Given this list of marker genes DLK1, ALG6, SCAPER, SETX, NPHS1, SDCCAG8, CEP19, CAV1, LIPA, FDFT1, RAI1, PNKP, TTC8, BBS10, NUP107 (NCBI Gene Id 57122), IFT56 (intraflagellar transport 56), CELA2A, PIK3R5, ALB, CAV3, PNLIP, CYP7B1, STX5, DYRK1B, CEP290, LRP6 (NCBI Gene Id 4040), PMM2, NPHP1 (nephrocystin 1), LDLRAP1, PLAAT3, EMD, TBL1X, MKS1 (MKS transition zone complex subunit 1), PHKA2, FLII, SYNE1, ABCB4, ALG9, DGAT1, GALK1, APOC3, PPARG, RTL1, APOA5, MEG3, SC5D, APOA2, BSCL2, HTT, TBCK, PEX12, LIPC, MKRN3 (NCBI Gene Id 7681), PSAP, KIF12, UBE3B, EPHX2, IFT172, WDPCP, PWRN1, TRIM32, FHL1, TNPO3, CAVIN1, CREB3L3, DEAF1, ABCA2, PYGL, TNFSF15, GPIHBP1, BBS4, IQSEC2, FLCN, NGLY1, ANGPTL3, APOA1, LCAT, PCYT1A, SLC2A3, ATAD3A (NCBI Gene Id 55210), RSPO1, BBS12, GBA1, MKKS, IRF5, TMEM43, PWAR1, LZTFL1, LPL, BBIP1 (BBSome interacting protein 1), PHKG2, PSMB8 (NCBI Gene Id 5696), SPIB, BBS2, NPAP1, HERC2, SLC7A7, CETP, CFAP418, MYO5B, COG4, IFT27, SYNE2, APOB, ABCG8, ALG12, IL12A, APOC2 (NCBI Gene Id 344), AGPAT2, AIP, OCRL, PCSK9, POU2AF1, ABCA1, DIO1 (iodothyronine deiodinase 1), LMNA, TMEM199, SCLT1, ATP6AP1, GPR101, LDLR, PPP1R17, JAG1, DHCR7, SLC25A36, GHR, SMPD1, BBS7, SCARB2 (NCBI Gene Id 950), NSDHL, IL12RB1, SNORD116-1, CCDC115, ARL6, PHKB, MMEL1, FOS, BBS9, APTX, IFT74, SLC25A13, MTTP, SNORD115-1, SLC37A4, TTPA, B4GALT1, APOE, DHCR24, BBS1, CYP27A1, MSMO1, CYP7A1, UBR1, EBP, TDP1, GALNT2, MEF2A, ALMS1, SAR1B, BBS5, HSD3B7, ABCG5, CYP11A1, MAGEL2, TSHB, here is a description of the gene set: Any deviation from the normal concentration of cholesterol in the blood circulation. Human Gene Set: HP_ABNORMAL_CIRCULATING_CHOLESTEROL_CONCENTRATION Abnormal circulating cholesterol concentration studied in species Homo sapiens